The following is a description of a gene set: Regulation of gene expression in early pancreatic precursor cells studied in species Homo sapiens Human Gene Set: REACTOME_REGULATION_OF_GENE_EXPRESSION_IN_EARLY_PANCREATIC_PRECURSOR_CELLS, and this is the list of marker genes: ONECUT1, PDX1, FGF10, NKX6-1, NR5A2, PTF1A, HNF1B, ONECUT3